Given this list of marker genes AKR1C3 (aldo-keto reductase family 1 member C3), PRKAA1, LPCAT1, KLHL25, PDGFB, BMP2, GPLD1, MIR342, DCAF5, ADORA1, UGT1A3, MIR548P, ORMDL2, PDE8B, APOC1, APOE, MFSD2A, PLIN5, UGT1A6, CCDC3, SPHK1, MIR1-1, UGT1A9, SNAI1, MIR30C1, PDGFA, IL1B, APOC2 (NCBI Gene Id 344), MIR192, WNT4, UBR4, ASXL3, FMC1, MIR132, ALK, UGT1A7, CH25H, MIR27B, APOA2, SNAI2, HCAR1, CIDEA, FMO1, SOX9, ATP1A1, FMO4, GPER1, HCAR2, UGT1A1, WDTC1, MIR9-1, CEACAM1, NCOR1, TNF, DKK3, TMX1, GGCX, REST, ACACB, APOBEC1 (apolipoprotein B mRNA editing enzyme catalytic subunit 1), CIDEC, NFKB1, SREBF1, UGT1A4, MIR204, BMP5, UGT1A10, PIBF1, ORMDL3, CYP7A1, INSIG1, APOD, C7orf50, CRTC3, LPIN1, ENDOU, APPL2, DKKL1, ERLIN2 (ER lipid raft associated 2), ABCA2, SLC22A13, SIRT4, ANGPTL4, PROX1, MIR185, INS, MIR27A, NR0B1, BSCL2, SIRT1, ORMDL1, MIR206, ACADVL, FMO2, MIR33A, PIK3CG, DGAT2, SCAP, FBXW7, UGT1A8, TRIB3, ACADL, INSIG2, SIK1, APOC3, ERLIN1, SERPINA12 (NCBI Gene Id 145264), AKT1, PRMT3, ADRA2A, MIR766, SORL1, ETFBKMT, PDE3B, MALRD1, FGF19, GFI1, BRCA1, MIR98, here is a description of the gene set: Any process that stops, prevents, or reduces the frequency, rate or extent of the chemical reactions and pathways involving lipids. studied in species Homo sapiens Human Gene Set: GOBP_NEGATIVE_REGULATION_OF_LIPID_METABOLIC_PROCESS